The following is a description of a gene set: species: Homo sapiens Human Gene Set: DESCARTES_MAIN_FETAL_THYMOCYTES The gene expression program underlying the specification of human cell types is of fundamental interest. The study authors generated human cell atlases of gene expression and chromatin accessibility in fetal tissues. For gene expression, the study authors applied three-level combinatorial indexing to >110 samples representing 15 organs, ultimately profiling ~4 million single cells. The study authors leveraged the literature and other atlases to identify and annotate hundreds of cell types and subtypes, both within and across tissues. Our analyses focused on organ-specific specializations of broadly distributed cell types (such as blood, endothelial, and epithelial), sites of fetal erythropoiesis (which notably included the adrenal gland), and integration with mouse developmental atlases (such as conserved specification of blood cells). These data represent a rich resource for the exploration of in vivo human gene expression in diverse tissues and cell types. from publication Cao J, O'Day DR, Pliner HA, Kingsley PD, Deng M, Daza RM, Zager MA, Aldinger KA, Blecher-Gonen R, Zhang F, Spielmann M, Palis J, Doherty D, Steemers FJ, Glass IA, Trapnell C, Shendure J (PMID 33184181) Marker genes curated from the annotated cluster as represented in the Descartes Human Gene Expression During Development database., and this is the list of marker genes: BCL11B, MDM4, CLCN3P1, ELOVL4, DGKA, DOC2GP, PDE7A, LINC01749, TCF12, PDSS1, IDNK, NFATC3, GRAP2, SLC8A1-AS1, RPL34-DT, TRAT1, IKZF2, RHOH, CCR9, LCT-AS1, MCPH1, LINC02789, CEP128 (NCBI Gene Id 283580), PXYLP1, SEPTIN6, TFDP2, ACSM6, LINC02273, TRAJ20, RPS3AP19, CHD1, ANKRD36BP2, UBASH3A, CCND3, LDLRAD4, LINC01221, NT5C3AP2, THEMIS, ARHGEF18-AS1, WAKMAR2, LINC01281, SH2D1A, ARHGAP19-SLIT1, MAP3K14-AS1, PITPNM2, DLEU7, LINC01882 (long intergenic non-protein coding RNA 1882), LEF1, TCF7, TOX2, HMGB1P19, HDAC7, SPOCD1, RAG2, ANTXRLP1, TRD-AS1, LINC00426, ACSF3, CD1E, MZB1, RNU6-242P, BOLL, CALN1, ATF7IP2, LINC00649, TBC1D19, ITPKB-IT1, MTA3, CD8A, LINC01222, LINC02520, CYP2U1, TSHR, PTCRA, LINC00954, LETM1, RASL11A, CAMK4, TNRC6C, SATB1-AS1, ARL5C, CD96, LZTFL1, RN7SKP110, CD38, CD1B, CD8B, UMLILO, IL20RB-AS1, ENSG00000236656, RNASEH2B, TNIP3, LINC02312, NEIL3, LEF1-AS1, MEAK7, RETREG1-AS1, GPRASP3P1, P2RX5, LINC02059, PRKCG, LCK, ENSG00000259097, TRBV28, PRKCQ-AS1, KCNA3, CD3G, CEP85L, CCNI2, SATB1, LINC01550, CD247, LINC02352, LINC01934, HMGN1P5, MIR646HG, TESPA1, CD1A, FMNL1-AS1, TRBC2, PGGHG, SSH2, PDCD1, FAM238B